The following is a description of a gene set: species: Homo sapiens Human Gene Set: GOCC_ATAC_COMPLEX A chromatin remodeling complex that regulates transcription via acetylation primarily of nucleosomal histones H3 and possibly H4. Shares the histone acetylation (HAT) module of GCN5/PCAF-ADA2-ADA3-SGF29 (or orthologs) with the related SAGA complex . Contains HAT subunits GCN5 or PCAF in a mutually exclusive manner. In addition to the HAT module contains DR1/NC2B, KAT14, MBIP, WDR5, YEATS2 and ZZZ3 or orthologs. Also regulates the activity of non-histone targets and orchestrates mitotic progression by regulating Cyclin A degradation through acetylation., and this is the list of marker genes: YEATS2, WDR5, TADA3, MBIP, ZZZ3, TADA2A, SGF29, KAT2A (NCBI Gene Id 2648), KAT14, MAP3K7 (NCBI Gene Id 6885), DR1, KAT2B, POLE4, POLE3 (DNA polymerase epsilon 3, accessory subunit)